Given this list of marker genes MTSS2 (MTSS I-BAR domain containing 2), DIRAS1, SLC8A2, KRT1, CBX5, BSDC1, MED19 (NCBI Gene Id 219541), PHLPP1, LURAP1, DYSF, C6orf141, SZRD1 (NCBI Gene Id 26099), CNIH2, COL9A2, CYP2B6, LSAMP, CCDC97, GAS7, CASTOR2, DMWD, GPRC5A, C19orf12, CES4A, CSF2RB, TREML1, RNASE13, MAT1A, FAM131B, PCDHB11, DDX31, NR1D1, RBM23, PPP1R9B, ZFC3H1, RSU1, TMEM222, ZDHHC15, TNFSF12, IKZF4, MPZ (NCBI Gene Id 4359), PKNOX2, LIX1L, LRRC59, STAC2, SMARCC2, CAMK1D, NOVA2, MLLT6, SNX29, PDLIM4, PDE1B, TBC1D10B, PAX5, LRP8, NFASC, INAVA, CTDSP1, H1-10, PLXNA4 (NCBI Gene Id 91584), CELF3, METTL9, FADS2, EN1, TCP11L1, CLSTN1, ZNF691, TMEM63B, SLC7A8, FKBP8, THRSP, PANX2, SNPH, STIM1, KMT2D, ELK1, BIRC2, NFIC, CAMKK2, KALRN, UBAP2L (ubiquitin associated protein 2 like), SHISAL1, PRC1, PVALB (NCBI Gene Id 5816), NFAT5, RBMS3, PRKACA, FOXC1, PPP2R5E, ACSL5, SLC25A42 (NCBI Gene Id 57831), TFAP2B, LRATD2, SF3A2, SPIN3, UBE2QL1, IHH, DYRK1A, MAP7D1, PHC2, DIRAS2, BMP1, PPT2, FOXE1, SERPINB7, MFRP (membrane frizzled-related protein), DVL3, ST13, SOX13, PLVAP, PSME3, DEF8, SH3TC2, PPP2R2D, PLA2G2D, MECP2, PTHLH, WNT3, MYL12A, RANBP10, APLNR, KCNC3, WNK4, GTPBP2, RERG, SCGB2B2, CDR2L, NLGN2, RSPO4, TMEM198, HMGA1, ITGA3, CNTNAP1, MIEN1, HEYL, C9orf57, CTNND1, ATAD3C, PRR23A, TMEM54 (NCBI Gene Id 113452), PPP2R1A, CXADR, PSMF1, CADM4, GATAD2B, VPS37D, NRG1, TLE3, WIZ, SPRR1B, AP2M1, TCF7, ANKRD52, ATP9A, SYNGAP1, TRAM2, SRF, SLC6A17, MNT, FBXO43, CNST, NFIX, MAP1A, POU2F2, GRHL2, NHERF2, COTL1, CHRNA4, SLC9A8, PEDS1-UBE2V1, PACS1, FOXP4, RAB11FIP4, PRR5L, EPB41L1, ADORA3, FAM234A, NAPA, CALR, SHANK2, SLC28A1, CPS1, ELAVL3, ANKRD26, FGF1, XYLB, TMEM151A, UBE2V1, MINK1, LRRC28, DUSP10, IGSF11, JPH4, BSN, FAM174B, LCE1B, AFAP1, CDK18, NAT16, ZBTB7B, MEX3A, PIK3R2, ZNRF2, APBA1, DPYSL5, ACTB, UBTF, CCDC102B, ARRB2, IL17RD, here is a description of the gene set: Genes predicted to be targets of miRBase v22 microRNA hsa-miR-4723-5p in miRDB v6.0 with MirTarget v4 prediction scores > 80 (high confidence targets). species: Homo sapiens Human Gene Set: MIR4723_5P from publication Chen Y, Wang X (PMID 31504780)